The following is a description of a gene set: Mouse Gene Set: GOBP_POSITIVE_REGULATION_OF_SKELETAL_MUSCLE_FIBER_DEVELOPMENT studied in species Mus musculus Any process that activates, maintains or increases the rate of skeletal muscle fiber development. Muscle fibers are formed by the maturation of myotubes. They can be classed as slow, intermediate/fast or fast., and this is the list of marker genes: Lmod3, Myf5, Shox2, Myog, Myf6, Actn3, Bcl2, Myod1